Given this list of marker genes GRAP, OSBPL10, GZMH, CA1, CYB5R3, TRRAP, MECR, PIERCE1, AAAS, UNC13A, ISY1, GKN1 (gastrokine 1), PCDHB10, PJA1, SYNJ1, TFCP2L1, TOR1B, RASGRP3, HPSE, LIFR, SAP30, ARHGAP30, PNKP, ZNF558, SLC17A9, C9orf50, C17orf58, MSANTD1, LINC00511, CSNK1E, NAPB, ANO10, SLC25A11, DNAJC5B, TPD52L2, TNKS1BP1, HCG4, DCUN1D5, GHSR, DSTYK, UBE2QL1, ACP6, TGFBR3, CCDC115, B4GALNT4, METRNL, AKR1B10 (NCBI Gene Id 9405), LRRIQ3, PTPRK, TTC8, ZNF219 (zinc finger protein 219), RNF130, ANGEL1, SPESP1, JAG2, HOXD4, MDP1, COQ9, SAP130, TCAP, TREX1, SHLD2, BAMBI, CFAP97, IFFO2 (intermediate filament family orphan 2), TTBK1, GLO1, SIX4, LPP, KRTAP13-2, TMCO6, KTI12, UBTD1, NLN, PRR23A, ARGLU1, CA10, MTUS1, TTBK2, MANBAL, CBY2, C1orf122, LZIC, CIMIP7, GPR183, CCSER2, AMBN, CYP46A1, WDPCP, KLF5, F2RL3, RADIL, MIF, CD300LB, MR1, B3GALT5, CACNA1S, GNAO1, FAM168B, RFESD, CLCN5, LSM7, BCL7B, IFNAR2, FBXL19, ZBTB8B, CFAP119, FSD2, GIMAP6, TMEM88, NICN1, PRR3, FXYD4, MLX, RNF135, GALK1, ULBP1, CCKAR, PRRC2C, PARS2, INPP4A, SPAG17, PGLS, CST7, KLK10, ANKRD37, PCGF1, LSR, SIAH2, ARPC1B, RAB42, LPCAT2, PLXND1, MYCBP2, ANXA2, NTF4, PCDHA12, SLC35B2, DESI2, AAMP, SNX15, CD27, PPIL2, GUCA1A, VWCE, PRIMA1, TPD52, NRDE2, SLC6A20, BZW2, FNBP1, TXNL4A, TUSC2, FUT7 (NCBI Gene Id 2529), SPATA33, KNL1, KAZALD1, RNF25, NPR1, MRPL45, SQOR, PPM1A, ROM1, TMEM203, HM13, GPC1, UNK, LMLN, KRTAP4-3, FFAR2, SLC9A2, ARHGEF6, SFTPB, DRD1, GDF15, MRPL10, ARPC4, GOSR1, ATP1B3, USP34, GADD45GIP1, CXADR, FLOT1, NUB1, SLC25A17, VCAN, EML2, CYB561D2, KPTN, HTT, PLIN3, DYNC2I2, RAB24 (RAB24, member RAS oncogene family), APP, IL21R, GPR89B, PRPH, INS, PLPBP, TOMM40, here is a description of the gene set: TGF-beta3 produced by developing Th17 cells induces highly pathogenic T cells that are functionally and molecularly distinct from TGF-beta1-induced Th17 cells. The microarray data represent a distinct molecular signature for pathogenic versus non-pathogenic Th17 cells. Genes down-regulated in comparison of CD4 T cells treated with TGFB1 versus those treated with TGFB3 treated with IL6 and IL23A. Human Gene Set: GSE39820_TGFBETA1_VS_TGFBETA3_IN_IL6_IL23A_TREATED_CD4_TCELL_DN from publication Lee Y, Awasthi A, Yosef N, Quintana FJ, Xiao S, Peters A, Wu C, Kleinewietfeld M, Kunder S, Hafler DA, Sobel RA, Regev A, Kuchroo VK (PMID 22961052) species: Homo sapiens